Given this list of marker genes PIK3IP1, CD55, RPL4, ECE1, ISG20, ZNF883, TSC22D3, MPZL3, SLC9A6, CCDC191, REEP5 (receptor accessory protein 5), FLOT2, RPS11, EEF1G, BIN1 (NCBI Gene Id 274), ELF4, GRASLND, IGBP1, ZNF302, SUSD3, NPDC1, RRP8 (NCBI Gene Id 23378), PARP11, TACO1, ZFYVE26, RASA3, TMBIM1, ARL4A, CARD6, TLR2, LEPROT, RGS1, C17orf49, ZDHHC9, AMIGO1, ZNF232, CYTIP, GIMAP2, RPL15, FAM32A, TARBP1, TMEM104, CASP1 (caspase 1), ICAM3, PLLP, PNP, INPP5D, AUTS2, RPLP2, IFIH1, PDE3B, TIMP1, PHB1, TMEM200A, RPS3, POLR1A, FYB1 (NCBI Gene Id 55458), LDLRAP1, RBM20, MAP7D1 (NCBI Gene Id 55700), NDRG2, NOP53, SMC1A, CCND2, DDB2, YIPF5 (Yip1 domain family member 5), CTSL, ITGB7, CAPZB, CUL2, NPAT, S100A6, DCTD, ANXA6, NOG, EDC3, MRPL11, PFDN5, FAM107B, SLA2, DEF8, EPHA4, RPS15A, SYNJ2BP, IL12RB1 (interleukin 12 receptor subunit beta 1), ZDHHC11, STK17A, TRABD, HLA-F, NKIRAS1, IL7R, ZMYND11, HLA-G, VIPR1, PIM2, STIM2, FBLN7, NSA2, BMPR2, PTPRN2, SMIM19, TOMM5, EPRS1, BTG1, CCT4, AGA, CAP1, OCIAD2, SHISA5, ASNSD1, RSAD2, FOXP1, SPIN3, GBP3, RPL32, R3HDM4, TUBA4A, EPSTI1, PINK1, RPL13A, GSTM1, RTCA, HLA-C, BTN3A3, OXA1L, HECA, GIMAP8, HLA-J, PLEKHA3, C14orf119, ADAMTS6, ZMAT2 (NCBI Gene Id 153527), VNN2, VPS13A, XKR6, RPS10P5, YTHDC2, PLEKHO1, CISD1, CACNA2D4, MEI1, RPL31, SPECC1, S100PBP, VCL, ZNF626, WNK3, ZNF395, TEX261 (NCBI Gene Id 113419), SGSH (N-sulfoglucosamine sulfohydrolase), IFITM1, BMS1, HEBP1, ADAT2, UPP1, RPL14, EIF3F, SIPA1, DNPH1, BAG3, S1PR2, RMND5B (NCBI Gene Id 64777), CRELD2, CD48, CIB1, GYPC, RPL10 (NCBI Gene Id 88324), SLC25A40, BUD31, RPS14, LRRN3, DUSP7, RPL13, COTL1, SNHG8, ENGASE, NLRC5, LIPA, SSR2, ADD3, CUTC, FAM171A1, PAG1, RNF213, ANK3, AP1G1, SPATA13, ZSWIM1, CCR7, PDE8A, KDM7A, RXYLT1, here is a description of the gene set: species: Homo sapiens Genes up-regulated upon CSF1 treatment: monocytes (3 days) versus macrophages (7 days). from publication Martinez FO, Gordon S, Locati M, Mantovani A (PMID 17082649) Monocytes mature tom acrophages in the presence of the lineage determining cytokine M-CSF. They can be further polarized into M1 or M2 macrophages with distinct functional properties. We used microarrays to detail the global programme of gene expression underlying macrophage maturation and polarization and identified distinct classes of up-regulated genes during this process. Human Gene Set: GSE5099_DAY3_VS_DAY7_MCSF_TREATED_MACROPHAGE_UP